The following is a description of a gene set: The action of a molecule that contributes to the structural integrity of the ribosome. Human Gene Set: GOMF_STRUCTURAL_CONSTITUENT_OF_RIBOSOME studied in species Homo sapiens, and this is the list of marker genes: MRPS7, RPS24, RPS10P5, RPL17, RPL39, MRPL34, MRPL41, RPL39P5, RPL31, MRPS30, MRPS34, MRPL11, LZTS1-AS1, RPS29, RPLP2, MRPS25, MRPL43, RPS2, RPL7, RPS4Y1, RPL3L, MRPL4, RPL19, RPS9, RPL41, MRPL21, MRPL15, RPL18A, MRPL49, MRPL46, MRPL57, MRPS15, RPL11, RPS6, MRPL37, RPL8, RPL13A (ribosomal protein L13a), MRPS6, RPL34, RPL24, RPS19, RPL35A, MRPL10, MRPL35, RPL18, FAU, RPS3, MRPL30, MRPL19, RPL37, RPL27, MRPS18C, RPS3A, RPLP0, RPL35, MRPS12, RPL10A, RPS27A, RPL38, MRPL54, MRPS14, MRPL14, RPS15, MRPS11, RPS17, RPS18, RNA5-8SN5, RPL36, RPL15, MRPL20 (NCBI Gene Id 64994), MRPL24, RPL29, MRPS24, RPS20, MRPL55, MRPS5, MRPL47, RPL22, MRPL17, RPL36AL (ribosomal protein L36a like), MRPL2 (NCBI Gene Id 65007), MRPL13, RPL28, RPL9, RPS23, RPL37AP8, RPL13, MRPL42, MRPS18B, RPL36A, MRPL33, MRPL18, RPS5, MRPS9, MRPL22, MRPL9, MRPS21, RPS14, MRPS35, RPL4, RPL14, RPS21, MRPL32, RPL5, RPL12, RPS27L, RNA5S1, RNA5S9, RPL22L1, RPL10, RPS11, RPL7A, RPL27A, RPL21, MRPL51, MRPS18A, RPS10, RPS26, RPL10L, MRPS16, RPL30, RPSA2, MRPS17, RPS8, DAP3, MRPS2, RPS15A, MRPS31, RPLP1, MRPL36 (NCBI Gene Id 64979), RSL24D1, RPS28, RPL37A, RPS4X, MRPL27, RPL6, MRPS23, SRBD1, MRPL3 (NCBI Gene Id 11222), RPL23A, RPL7L1, MRPL52, RPL26L1, RPS7, MRPL23, MRPL16, MRPL45, MRPS22, RPS13, RPL39L, RPL13AP3, MRPS33, RPL32, RPS4Y2, RPL3, RPSA, RPLP0P6, RPS27, RPS25, MRPL28, MRPL12, RPS16, MRPL1, RPL26, RPL23, UBA52, RPS12